The following is a description of a gene set: Human Gene Set: REACTOME_SYNTHESIS_OF_PIPS_AT_THE_PLASMA_MEMBRANE species: Homo sapiens Synthesis of PIPs at the plasma membrane, and this is the list of marker genes: RAB5A, MTMR1, PI4K2B, SYNJ2, PIP4K2B, PIK3R6, PTPN13, MTMR2, PLEKHA3, PIK3CD, PIP4K2C, OCRL, PLEKHA6, SBF2, PIK3R1, RAB14, PIK3CG, PIP5K1A, ARF1, PIP4K2A, PLEKHA5, PIK3C2B, RAB4A, INPP5D, SYNJ1, RUFY1, PIK3CA, PIK3C2G, MTMR8, MTMR3, INPP4B, BMX, MTMR9, PIK3CB, PIK3C2A, PIP5K1C, PIK3R5, PIP5K1B (phosphatidylinositol-4-phosphate 5-kinase type 1 beta), MTMR6, PLEKHA8, PLEKHA1, INPP5J, INPP4A, PLEKHA4, INPPL1, PI4K2A, MTMR14, MTM1, PIK3R2, PTEN (phosphatase and tensin homolog), INPP5K, PIK3R3, PLEKHA2 (NCBI Gene Id 651347)